The following is a description of a gene set: studied in species Mus musculus Mouse Gene Set: GOBP_PHOTORECEPTOR_CELL_DEVELOPMENT Development of a photoreceptor, a cell that responds to incident electromagnetic radiation, particularly visible light., and this is the list of marker genes: Ift20, Nr2e3, Cfh, Rom1, Rorb, Gabrr2, Trpm1, Poc5, Ahi1, Mir96, Th, Grk1, Dzank1, Crb2, Pde6c, Gngt1, Prkci, Thy1, Mir124a-1, Samd11, Miat, Mfrp, Rp1, Cabp4, Bbs4, Prph2, Fscn2, Tug1, Rpgr, Ntrk2 (neurotrophic tyrosine kinase, receptor, type 2), Mir183 (microRNA 183), Cfap418, Rp1l1, Mfsd2a, Ift140, Pdgfb, Pax6, Bhlhe23 (basic helix-loop-helix family, member e23), Mir124a-2 (NCBI Gene Id 723950, microRNA 124a-2), Mir182, Bbs1, Nphp4, Ift56, Vegfa, Tulp1 (TUB like protein 1), Gnat2, Nphp1, Rabl2, Samd7, Cep290, Fam151b, Rpgrip1, Thrb, Gnat1, Pcare, Nrl, Ush1c, Rdh13, Crb1, Arl3, Naglu, Prdm1, Alms1, Rpgrip1l, Olfm3, Dio3, Cngb1, Cnga3 (cyclic nucleotide gated channel alpha 3), Tmem67, Hcn1, Cdhr1